The following is a description of a gene set: species: Mus musculus Any process that modulates the frequency, rate or extent of peptidyl-tyrosine autophosphorylation. Mouse Gene Set: GOBP_REGULATION_OF_PEPTIDYL_TYROSINE_AUTOPHOSPHORYLATION, and this is the list of marker genes: Nrg1 (neuregulin 1), Grem1, Ctnnd1, Cav1, Iqgap1